Given this list of marker genes GDI2, CLNK, MED24, HSP90AA1, ITGB5, CDKN2A, SAYSD1, CCT3, ARFGAP3, PHLDA2, DNMBP, SLC44A1, ABCE1, SLC16A6, CCT6A, SMAD2, MAN1A1, GBF1, WNT6, HCCS, LITAF, BMP2K, CNTNAP2, MFSD14A (NCBI Gene Id 64645), PTP4A3, RAD23B, QSOX1, BTBD2, PSRC1, CYB5B, VNN2, EBI3, SIL1, ROCK2, SWAP70, YBX2, LYN, NIN (NCBI Gene Id 57681), TRIP10, DCXR, SSBP4, RHBDF1, RBM3, SBK1, CNTN6, CCNB2, ADAM17, PRDX1, HNRNPH1, SPAG4, IRX5 (iroquois homeobox 5), ALYREF, GFOD2, PDSS1, ILKAP, FAM98A, IL10, ATP6V0D1, RRM2B, POLA2, TOPBP1 (NCBI Gene Id 11073), KIF20A, CPLX4, SLC37A1, ITGB2, ITCH, MIF4GD, PPIB, TMEM131, PARN, RPS16, HACD3 (NCBI Gene Id 95112), IL10RA, WDFY3, TYMS, RAD51AP1, PTPN22, YTHDF1, LAIR1, UEVLD, ARHGAP21, CRYBG3, JAK2, TNFRSF21, ZNF474, VDAC1, CD300C, LTF, RNF38, TXNDC5, DLX3, HBG2, ACP3 (acid phosphatase 3), TLR1, POSTN, DGKZ, SLC35C2, TMEM79, HEY1, B4GALT1, ALDH2, EWSR1, STRN4, PROC, HIBADH, PDIA6, TGFBR1, SMC4, UBE2J1, ACTG2, HP, RBM5, PREP, RBFOX1, POLD2, SMAP2, SERPINF1, CACNA1H, SLC4A7, LHB, HIF3A, ST3GAL4, HAUS3, SPIB, PJA2, TMEM51, UGDH, KRTAP15-1, MMP2, CAVIN2, TRIM60, RBM14, CASP12, RAD51, RPL12, BRD4, HCAR2, ABCG2, SLC13A3, INSM1, KDF1, RBM6, AP2B1, APCDD1, FOXI1, TK1, TLR9, NAB2, XRCC6, FMO3, PPP6R3, PMPCA, SLC3A1, ATP5PO (NCBI Gene Id 539), GZMA, GABRR1, RAC2, SLC9A8, C3orf52, JMJD8, ABCB6, IRS4, DHX40, MRAS, ADAMTS4, SLC35F5, ASPSCR1, SPC25, CTSS, PPBP, FHDC1, MSH6, ACVR1B, HCK, UBE2D3, CYP51A1, CDK1, COX7A2, NR0B2, RRM1, NTN3, WDR12, C1QA, TPBG, ZNF821, PLTP, RND3, PIK3CG, GUCY1B1, LMO4, CSDC2, LTN1, CD48, SLC30A4, MBNL1, RPL6, HAUS6 (HAUS augmin like complex subunit 6), HNRNPM, MLH3, TWIST1, here is a description of the gene set: mouse primary BMDCs were stimulated with tlr ligands and gene expression changes were profiled on Affymetrix arrays species: Homo sapiens Genes down-regulated in comparison of dendritic cells (DC) stimulated with LPS (TLR4 agonist) at 24 h versus DC cells stimulated with CpG DNA (TLR9 agonist) at 24 h. from publication Amit I, Garber M, Chevrier N, Leite AP, Donner Y, Eisenhaure T, Guttman M, Grenier JK, Li W, Zuk O, Schubert LA, Birditt B, Shay T, Goren A, Zhang X, Smith Z, Deering R, McDonald RC, Cabili M, Bernstein BE, Rinn JL, Meissner A, Root DE, Hacohen N, Regev A (PMID 19729616) Human Gene Set: GSE17721_LPS_VS_CPG_24H_BMDC_DN